The following is a description of a gene set: Any process that activates or increases the frequency, rate or extent of the directed movement of potassium ions (K+) into, out of or within a cell, or between cells, by means of some agent such as a transporter or pore. studied in species Mus musculus Mouse Gene Set: GOBP_POSITIVE_REGULATION_OF_POTASSIUM_ION_TRANSPORT, and this is the list of marker genes: Kcnmb1, Wnk4, Rnf207, Lrrc52, Kif5b, Gal, Stk39, Wnk3, Kcne1, Rgs7, Kcnj2, Ank2 (ankyrin 2, brain), Akap7, Kcnn2, Kcne5 (NCBI Gene Id 66240), Atp1b2, Actn2, Lrrc55, Abcc8, Trem2, Akap6, Dpp6, Akap9, Lrrc26, Wnk2, Edn3 (NCBI Gene Id 13616), Hbp1, Kcnq1, Flna, Oprk1, Ano6, Galr2, Adrb2, Kcnh2, Kcnc1, Adora1, Nppa, Atp1b3, Kcnc2, Wnk1, Atp1b1, Cxcl1, Amigo1, Fhl1, Kcnip2, Dlg1, Lrrc38